The following is a description of a gene set: studied in species Homo sapiens Tandem pore domain potassium channels Human Gene Set: REACTOME_TANDEM_PORE_DOMAIN_POTASSIUM_CHANNELS, and this is the list of marker genes: KCNK13, KCNK10, KCNK1, KCNK18, KCNK6, KCNK3, KCNK4, KCNK7, KCNK9, KCNK2 (potassium two pore domain channel subfamily K member 2), KCNK17, KCNK16